The following is a description of a gene set: A specialized secretory lysosome that is present in cells with cytolytic capability such as cytotoxic T lymphocytes and natural killer cells. Cytolytic granules mediate the storage and regulated excretion of lytic molecules for killing of target cells. species: Mus musculus Mouse Gene Set: GOCC_CYTOLYTIC_GRANULE, and this is the list of marker genes: Gzmc, Gzmd, Stxbp2, Rnf19b, Serpinb1a, Arl8b, Gzmg, Gzme, Nkg7, Gzmf, Kif5b, Lamp1, Gzmn, Srgn, Gzmb, Calr, Tial1, Prf1